The following is a description of a gene set: Human Gene Set: GOBP_MIDBODY_ABSCISSION The process by which the midbody, the cytoplasmic bridge that connects the two prospective daughter cells, is severed at the end of mitotic cytokinesis, resulting in two separate daughter cells. species: Homo sapiens, and this is the list of marker genes: CHMP7, CHMP4A, PDCD6IP, CHMP3, VPS4B, AURKB, CHMP6, ZFYVE19, CHMP4B, CEP55, MTMR4, CHMP4C (charged multivesicular body protein 4C), CHMP4BP1, MTMR3, MITD1, IST1, SPART, VPS4A, CHMP2A, CHMP2B, CHMP1A, KIF20A, CHMP1B, CHMP5